The following is a description of a gene set: Binds to and modulates of the activity of the enzyme calcium-dependent protein serine/threonine phosphatase. species: Homo sapiens Human Gene Set: GOMF_CALCIUM_DEPENDENT_PROTEIN_SERINE_THREONINE_PHOSPHATASE_REGULATOR_ACTIVITY, and this is the list of marker genes: RCAN2, PPP3R2, RCAN1, PPP3R1, RCAN3